The following is a description of a gene set: from publication Tabula Muris Consortium (PMID 32669714) species: Mus musculus Mouse Gene Set: TABULA_MURIS_SENIS_TRACHEA_ENDOTHELIAL_CELL_AGEING, and this is the list of marker genes: Prdx1, Emc2, Rps3a1, Rhoc, Bsg, Klhdc2, Prelid1, Vdac2, Arpc3, Tex261, Lxn, Tmsb10, Selenow, BC031181, Tpgs1, Col18a1, Rrp9, Dhrs7, Rpl6, Arhgdib, Mgll, Mis18a, Tbcb, Wdr12, Ccdc47, Fis1, 1700008J07Rik, Serpina3n, Spcs2, Hmox2, Dynlrb1, Napa, Eef1d, Tmem109, Psma2, Pfn1, Pglyrp1, Rplp0, Cracr2b (calcium release activated channel regulator 2B), Lsm2, Efhd1, Msl1, Arl4a, Clta, Cavin3, Timm17a (NCBI Gene Id 21854), Psmb10, Sdf4, Mrpl22, Trappc13, Pomp, Psma1, S100a16, Atp6v1g1, Atp5pb (ATP synthase peripheral stalk-membrane subunit b), Psmb8, Mlf2, Rpl3, Ssbp4, Aldoa, Ciao2a (cytosolic iron-sulfur assembly component 2A), Tmem204, Akt1s1, Naca, Eva1b, Snx15, Txn2, Ahsa1, H2aj, Copz2, Map1lc3a, Phb2, Fbxo4 (F-box protein 4), Ptms, Malat1, Rps9, Tmem50a, Gm9320, H2bc4, Dpy30, Txnl4a, Ptma, Atp13a1 (NCBI Gene Id 170759), Ntn1, Rpl13a, Vps29, Tspan17, Clic1, Rps24, Ssu72, Grap, Stk16, Lamtor4, Scn1b, Nabp2, Sar1b, Prss23, Urod, Fam3a, Ifi27, Rbm3, Emc10, Use1, Serpine2, Fth1, Phax, Ptprj, Oaz2, Ube2e1, Glrx3, Gstp1, Rpl13, Rab13, Psma7, Prpf40a, Mrpl15, Cldn5, 2810013P06Rik, Pcbp2, Med28, Sncg, Rpl14, Tle5, 2510002D24Rik, Ccdc85b, Srp14, Cry2, Pcp4l1, Rnf7, Smco4, Timm44, Ppp1r11, Eif3f, Trir, Lmo2, Ybx1, Bloc1s4, Pnn, Icam2, Surf1, Mrps24, Cox7a2l, Ngdn, Cnppd1, Lyve1, Igfbp5, Tmed9, Laptm4a (NCBI Gene Id 17775), Bcas2, Stmn2 (stathmin-like 2), Denr, Sf3b4, Syf2, Emc4, Slc50a1, Echs1, Cops6, Hdac7, Ift43, Commd3, Lims1, Cfl1, Rps4x, Spart, Cox5a, Mdh1, Rbm8a, Selenom, H2ac25, Crip2, Flt4, 4933434E20Rik, Ndufb7, Elof1, Snf8, Egfl7, Npc2, Pkig, Rps3, Rpsa, Gng11, Stoml2, Rnf166, Cd9, Inka1 (inka box actin regulator 1), Fgl2, Bst2, Ppp1ca, Myct1, Hs3st1, Lamtor1, Plscr2, Ecscr, Skap2, Meox1, Ccdc124, Ap2s1, Gpx4, Tmem59, Cyba, Klf2, Smim12 (NCBI Gene Id 80284), Isca2, Rabac1, Nedd8, Hsd3b7, Zfp830, Ppib